Given this list of marker genes KIF2C, DCLRE1A, NET1, SPAG5, B4GALT2, PRPSAP1, TOB1, ACAT1, ADK, MATK, LINC00342, GSTP1, SLC27A2, NEDD4, CCNE1, SLC7A1, USP14, KRT4, PLK4, GALE, RANBP1, MTHFD1, EXO1, CD1C, HPRT1, WDR43, FOXM1, NUDT1, OAT, CCL17, SKP2, NPM3, SLC39A8, PSMG1, ARHGAP11A, NME1, DLGAP5, GNAQ, BUB1B (BUB1 mitotic checkpoint serine/threonine kinase B), AKR1B1, DUT, LY96, CSE1L, AHNAK, FKBP4, ADCY3, AHCY, GPSM2, EFCAB11 (NCBI Gene Id 90141), CENPE, CDC25C, CKS2, H4C13, CDKN3, ANP32E, ALDH7A1, TRAP1, CHAF1A, LGALS3BP, COQ2, MPHOSPH6, NUP155, NEMP1 (nuclear envelope integral membrane protein 1), DTYMK, PSCA, ZWINT, TTF2, GCLC, MS4A1, MT2A, LDHA (lactate dehydrogenase A), PFKM, CYP1B1, ACAT2, STIL, CKS1B, BAG2, CHEK1, ATIC, SIGMAR1, GLDC, CTNNAL1, TRIP13, MEST, IARS1 (NCBI Gene Id 3376), TIMELESS, AKAP1, NCAPH, SLC29A1, HLTF, TUBG1, GTSE1, TMEM106C, CDC6, TUBA4A, SLC31A1, FRMD4B, GMPS, SPRY2, LIG1, CCT5, TRAF3IP2, NDC80, GART, PAICS, H2AX, PHGDH, BCAT1, RNASEH2A, KIF20B, CENPA, RPP40, GINS1, PTGER2, GCLM, CERS6, RABEPK, KIF23, ABCF2, MDFIC, HMMR, CIT, CCNE2, GSS (glutathione synthetase), HADH, BLM, SORL1, GGH, UBE2C, UMPS, PRIM1, PTPN22, CCNB1, CDC45, KIF11, TOP2A, RRAGD, KCNJ4, TRAT1, DHFR, ACOT7, ZNF423, TFDP1, RFC4, KAT2A (NCBI Gene Id 2648), C1QBP, IMPDH2, PRIM2, COPS3, ETFB, FABP5, WWOX, BDH1, POLE2, TRIM14, PKMYT1, IFT25 (NCBI Gene Id 51668), POP7, CDK1, POLE, CENPF, TAF1B, LCP1, TSR1, HSPB1, WAPL, IGFBP7, PPIH, ANXA4, SACS, EXOSC7, TK1, DBF4, SLC37A4, POLA1 (NCBI Gene Id 5422), MTHFD2, MACIR, RFC5, ESPL1, SIVA1, MPDU1, FANCG, TTK, GCSH, UNG, MELK, PTPRU, CDC7, BUB1, CDK4, LAPTM4B, KNTC1, TPX2, PRKAR2B, NDUFS5, OIP5, TXN, SLC39A14, ZNF248, here is a description of the gene set: TCF-1 is an HMG family transcription factor which is known to be critical for T cell development. We discovered that it has a unique role in suppressing malignant transformation of developing thymocytes at early stages. We identified ID2 and LEF-1 as key TCF-1 target genens in tumor suppression. We used microarrays to detect gene expression changes in WT and TCF-1 deficient DN3 thymocytes as well as T cell lymphoma cells developed in TCF-1 KO mice. species: Homo sapiens Genes down-regulated in DN3 thymocytes: wildtype versus TCF7 knockout. Human Gene Set: GSE33292_WT_VS_TCF1_KO_DN3_THYMOCYTE_DN from publication Yu S, Zhou X, Steinke FC, Liu C, Chen SC, Zagorodna O, Jing X, Yokota Y, Meyerholz DK, Mullighan CG, Knudson CM, Zhao DM, Xue HH (PMID 23103132)